Given this list of marker genes CDK4, CCND2, E2F3, CCND3, RB1, E2F2, CDK6, CCND1, E2F1, here is a description of the gene set: studied in species Homo sapiens Human Gene Set: KEGG_MEDICUS_PATHOGEN_EBV_EBNA3C_TO_CELL_CYCLE_G1_S_N00483 Pathway Definition from KEGG: EBNA3C -> (CCND+CDK4/6) -> RB1 // E2F EBV EBNA3C to cell cycle G1/S. Pathway ID: N00483. Pathway type: Pathogen. Pathway class: nt06165 Epstein-Barr virus (EBV).